The following is a description of a gene set: A complex of collagen trimers such as a fibril or collagen network. species: Homo sapiens Human Gene Set: GOCC_COMPLEX_OF_COLLAGEN_TRIMERS, and this is the list of marker genes: COL4A4, COL4A1, COL4A2, COL7A1, COL8A1, COL4A3, COL11A1, COL5A1, COL4A5, COL1A1, COL27A1, COL11A2, COL28A1, COL10A1, COL5A2, LUM, COL4A6, COL1A2, COL5A3, COL2A1, COL8A2, COL3A1